Given this list of marker genes NID2, EPHA3, DAB2, DUSP3, CCL28, PTPN1, ILK, PTPRO, ARHGEF7, CX3CL1, FUT1, ACTN4, MSLN, RAB1A, MAP4K4 (mitogen-activated protein kinase kinase kinase kinase 4), PREX1, EPHA1, LYVE1, PRKCE, VTN, ANGPT2, CIB1, FZD7 (NCBI Gene Id 8324), POSTN, BVES, THBS1, PPM1F, FERMT1, ITGB4, ECM2, CRK (CRK proto-oncogene, adaptor protein), SDC4, EPB41L5, BST1, MUC4, DOCK5, FREM1, RASA1, EMILIN1 (NCBI Gene Id 25883), VCAM1, SRF, HPSE, CTNNB1, MIR183, PRKX, PDGFB, HAS2, RAC1, CARMIL1, APOD, FER, PKHD1, AXL, CCDC80, TRIP6, PKP2, FERMT2, ARPC2, MICALL2, LIMCH1, MKLN1, RHOA, VWC2, ARL2, RSU1, SLC9A1, GBP1, SMAD6, SRGAP2 (NCBI Gene Id 440748), CFL1, MIR503, THY1, AP1AR, P4HB, FGA, MERTK, C1QBP, ITGA1, CCR7, NID1, LPXN, PTPRK, WNT1, PIK3CB, VWA2, ITGA9, JAG1, EFEMP2, CASS4, DDR1, FLNA, MACF1, CDK6, ITGA2, TSC1, KIF14, ZYX, MYOC (myocilin), LYPD3, VEGFA, RREB1, FGB, MELTF, ITGB3, RAC3, CCL25, WASHC2C, ABI3BP, TIMM10B (translocase of inner mitochondrial membrane 10B), STRCP1, WHAMM, ITGB5, ITGAL, DUSP22, ITGA4 (NCBI Gene Id 3676), COL3A1, MIR939, BCL2L11, S100A10, PPARD, ITGAX, LAMC1, SORBS1, STRC, TRPM7, L1CAM, CORO1A, ITGA8, MIR92A1, EGFL6, CDH11 (NCBI Gene Id 1009), FGG, EPHB1, SORBS3, TBCD, ITGB2, PIK3R1, POLDIP2, MDK, ADAM9, OLFM4, SPOCK1, STON1 (NCBI Gene Id 11037), PARVG, CORO1C, FOXF1, HRG, BRAF, COL17A1, VCL, VAMP3, ANXA2, TIAM1, ITGA7, DLC1, HOXD3, EMP2, LAMA5, CD3E, ACTN2, BCL2, ITGAE, PKD1, TACSTD2, CDKN2A, RHOD, SNED1 (NCBI Gene Id 25992), CASK, MMP12, ABL1, PEAK1, LIMS1, ATXN3, PIP5K1A, LAMB1, SIGLEC1, NPY2R, ITGAD, PLAU, DMP1, CCL21, BCR (BCR activator of RhoGEF and GTPase), MYADM, DEFB118, THSD1, ATP1B2, MSLNL, CLASP2, THBS3, CALR, ADAM15, SGCE (sarcoglycan epsilon), FZD4, PTK2, AGR2, DISC1 (DISC1 scaffold protein), GFUS, PTPRA, JAK2, DOCK1, ADAMTS9, TTYH1, PPFIA2, VWF, FAM107A, FN1 (NCBI Gene Id 2335), ADAMTS12, SPOCK2, UNC13D, COL26A1, NEXMIF, TESK2, PARVA, ROCK1, CSF1, PTEN, AJAP1, TNFRSF12A, LEF1, NRP1, COL5A3, ITGAV, TMEM8B, JAM3, CCN2, KANK1, CRKL, HACD1, RADIL, FERMT3, NPY, ITGAM, CCN1, LIMS2, EGFLAM (EGF like, fibronectin type III and laminin G domains), SERPINE1, ITGB7, ALOX15, EPHB3, ITGA3, HTN1, ARHGAP6, COL1A1, ITGA6, PLPP3, AKIP1, SPRY4, PLG, PPFIA1, ITGA10, SVEP1, GSK3B, ACVRL1, ACTN1, NF1, ANGPTL3, CLASP1, SKAP1, OTOA, TEK, COL16A1, SRCIN1, SRC, ITGB1BP1, GAS6, SLK, ITGA11, PECAM1, CDH13, PDPN, DAG1, GPM6B, SEMA3E, ITGA2B, FAT2, EFNA1, STK4, JUP, CAMSAP3, ADAMTS13, NF2, MINK1, EFNA5, EPDR1, ACTG1, PLET1, MMP14, TAOK2, FBLN2, ONECUT2, CORO2B, PTPRJ, SMAD3, AJUBA, ITGB8, UTRN, EDA, TESK1, CDC42, CD63, RAC2, VIT, ANTXR1, MADCAM1, CDK5, CD96, ACER2 (NCBI Gene Id 340485), ITGA5, ACTN3, MIR192, EDIL3, TRIOBP, CD34, RRAS, ROCK2, RELL2, PTK2B, HOXA7, ITGB6, TLN1 (NCBI Gene Id 7094), WNT4, RIN2, TNXB, MYO1G, NPNT, CEACAM6, CSPG5, CD36, NDNF, NTN4, NOTCH1, NEDD9, ITGBL1, WDPCP, BCL6, PXN, BCAM, MYF5, APOA1, CTTN, TECTA, PARVB, SFRP1, GREM1, KDR, DMTN, FBLN1, HSD17B12, RCC2, PHLDB2, CD44, FBLN5, TNN, LDB1, ITGB1, TYRO3, MIR29C, ONECUT1, DAPK3, PLEKHA2, COL13A1, GCNT2, ANGPT1, COL8A1, here is a description of the gene set: The attachment of a cell to the underlying substrate via adhesion molecules. Human Gene Set: GOBP_CELL_SUBSTRATE_ADHESION species: Homo sapiens